Given this list of marker genes Kitl, Ccr3, Vegfa, Ccl11, Rac1, Vegfd, Rin3, Ccl5, Stat5b, Chga, Rac2, Swap70, Vegfc, Pgf, Vegfb, Kit, Rabgef1, here is a description of the gene set: species: Mus musculus Mouse Gene Set: GOBP_MAST_CELL_MIGRATION The movement of a mast cell within or between different tissues and organs of the body.